Given this list of marker genes APPL1, STXBP3, GPC3, ADIPOQ, CLTCL1, TNF, MIR107, FGF19, POU4F2, IRS1, FGF21, MIR223, GRB10, OSBPL8, OSTN, ITLN1, PTH, PEA15, MAPK14, ENPP1, PRKAG2, CREBL2, RAP1A, MEF2A, MIR143, MIR103A1, NFE2L2, TERT, LEP, CERS1, RNASEL, GSK3A, AKT2 (AKT serine/threonine kinase 2), PIK3R1, ERFE, RHOQ, C1QTNF12, PID1, ASPSCR1, ARPP19, OPN3, SIRT6, CAPN10, IRS2, RTN2, PTPN11, SELENOS, IGF1, SLC25A27, AKT1 (NCBI Gene Id 207), SLC1A2, INS, OCLN, APPL2, KLF15 (NCBI Gene Id 28999), INSR, PLA2G1B, SORBS1, PRKCI, HK2, here is a description of the gene set: Human Gene Set: GOBP_REGULATION_OF_D_GLUCOSE_IMPORT species: Homo sapiens Any process that modulates the frequency, rate or extent of the import of the hexose monosaccharide glucose into a cell or organelle.